Given this list of marker genes FBN1, GREM1, MICOS10-NBL1, LRPAP1, NRROS, GREM2, LTBP1, CD46, FBN2, DAND5, ZNF653, CER1, NBL1, here is a description of the gene set: Any regulation of signal transduction that takes place in the extracellular region. studied in species Homo sapiens Human Gene Set: GOBP_EXTRACELLULAR_REGULATION_OF_SIGNAL_TRANSDUCTION